Given this list of marker genes MCRS1, POT1, PINX1, ERCC4, PIF1, TEN1, ACD, here is a description of the gene set: Human Gene Set: GOMF_TELOMERASE_INHIBITOR_ACTIVITY Binds to and stops, prevents or reduces the activity of telomerase. studied in species Homo sapiens